The following is a description of a gene set: studied in species Homo sapiens Human Gene Set: GOBP_NEGATIVE_REGULATION_OF_CELL_SIZE Any process that reduces cell size., and this is the list of marker genes: UCN, MTOR, DEPTOR, TSC1, RDX, CFL1 (NCBI Gene Id 1072), AKT1S1, PTEN, RHOA (NCBI Gene Id 387), CAV3